Given this list of marker genes HIPK4, MUC6, NTN3 (netrin 3), MMP25, KRTAP5-1, APOB, CYFIP2, IL17C, CDH15, KCNH5 (potassium voltage-gated channel subfamily H member 5), PLA2G2D, TTC23L (NCBI Gene Id 153657), SAA4 (serum amyloid A4, constitutive), RAP2A, SLC14A2, LRRC43, WWTR1, PRSS27, MIR204, MROH1, PLPP7, PSMA2, TCF23, NTNG1 (NCBI Gene Id 22854), AQP1, LTBR, NDEL1, CHGA, NPY1R, OVOL3, FCAMR, PIGY, RBBP8NL, SCRG1, ACMSD, LRP5, HOXB3, GAL3ST3, TDRD5, TARM1, PUS7L, MIR302D, CLEC7A, CPNE4, UBE2Q2, SLC23A1, MS4A7, ANXA3, HCAR2, VSX2, PRSS41, RHOBTB1, SLC30A10, UNC5B, PKP1, BDKRB2, MYRIP, RAB38, ATP6V0E2, CDKL5 (cyclin dependent kinase like 5), CDH26, LEFTY1, PRRC2A, EFCC1, CETN1, EMX1, NAV2, MYO15A, FBXL22 (F-box and leucine rich repeat protein 22), BTN1A1, SORCS3, RNF186, SMPX, CSF2RBP1, BCL2L10, HSF5, BMP8A, TMEM45A, SLCO2B1, MYO18B, PELI3, KCNJ9, KCNT1, B4GALNT2 (NCBI Gene Id 124872), CLDN14, TMEM125, CCR10, FOXB2, MGAT3, ADAMTS16, C1QTNF2, LHX8, GJA8, MEMO1, RTL6, FGFBP3, TSPO2, PNCK, PNPLA1, HEBP1, XCR1, SLAMF9, C1QB, FGD6, ANKRD1, TRIM42, POPDC3, ZFR2, EPPK1, TRH (thyrotropin releasing hormone), PBLD, GALNT15, SLC27A5, PLIN5, SHISAL2A, CFAP52, SPATA7, PSMB11, TRDN, SIX4, SLC5A7, ALPG, ABLIM2, FRAS1, TMEM217, LRFN2, SLC22A18, NR2F2, CLCNKB, here is a description of the gene set: from publication Fernandez DR, Telarico T, Bonilla E, Li Q, Banerjee S, Middleton FA, Phillips PE, Crow MK, Oess S, Muller-Esterl W, Perl A (PMID 19201859) Genes up-regulated in CD4 T cells from healthy donors: activated by anti-CD3 and anti-CD28 versus nitric oxide treatment. CD3-positive T cells were negatively isolated from 10 SLE patients and 9 healthy controls without SLE. All of the SLE samples and control samples were compared with one another to identify baseline differences in expression due to the disease. Next, T cell preparations from 4 of the control subjects were stimulated with either Nitric Oxide (NOC-18) 600 uM for 24hr or stimulated through CD3/CD28 for 24hr to determine which genes were responsive to these signaling mechanisms. Here, we show that activity of the mammalian target of rapamycin (mTOR), which is a sensor of the mitochondrial transmembrane potential, is increased in SLE T cells. Activation of mTOR was inducible by NO, a key trigger of MHP which in turn enhanced the expression of HRES-1/Rab4, a small GTPase that regulates recycling of surface receptors through early endosomes. Expression of HRES-1/Rab4 was increased in SLE T cells and, in accordance with its dominant impact on the endocytic recycling of CD4, it was inversely correlated with diminished CD4 expression. HRES-1/Rab4 over-expression was also inversely correlated with diminished TCRζ protein levels. Combined with follow up studies, these results suggest that activation of mTOR causes the loss of TCRζ in lupus T cells through HRES-1/Rab4-dependent lysosomal degradation. Human Gene Set: GSE13887_ACT_CD4_VS_NO_TREATED_CD4_TCELL_UP species: Homo sapiens